The following is a description of a gene set: Human Gene Set: HP_ABNORMAL_CEREBELLAR_CORTEX_MORPHOLOGY Any structural anomaly of the cortex of the cerebellum. studied in species Homo sapiens Abnormal cerebellar cortex morphology, and this is the list of marker genes: PNPT1 (polyribonucleotide nucleotidyltransferase 1), ATP6V1B2, TBC1D24, POLG, TWNK